Given this list of marker genes ZNF83, RPA1, NOTCH2NLA, PDGFA, RBFOX2, LLGL2, NTAN1, TPR, TTC3, AHSA2P, MAPK13, TLR5 (toll like receptor 5), DCPS, SAYSD1 (SAYSVFN motif domain containing 1), EXOC2, POGZ, RPS19, FNBP1, SPINT1, SOX13, DENND2B, DHRS7, PRRC2C, KDM5B, KLHL23, MGP, SEPHS1, KCTD3, ABHD3, DDR1, PRR15L, SREK1IP1, MATN2, INPP5A, MPZL1, IGF2, MARCHF3, PDCD4, TNFSF4, B4GALT3, ST14, ZSCAN18, IDUA, MMP11, CACNA1D, HNRNPA0, LAD1, ELP1, RPLP0, SREBF2, PLXNA2, CCZ1, CRNKL1 (NCBI Gene Id 51340), TTLL4, HIC2, MAP4K4, MEX3D, UBAP2, SOX9, S100A14, ABCC10, RABIF, NAP1L1, MYO5C, LMNA, PAIP1, ATP5MC2, RO60, ZNF143, NUP133, CLDN7, AHNAK, PIAS4, TMEM63A, STT3A, ADGRG1, RBM8A (RNA binding motif protein 8A), HOOK2, NRXN3, SMARCA1, F11R, ARHGEF3, NCOA3, PRP4K, PEG3, ADAR, PLPP2, SPINT2, EDEM3, C2CD5, BRD3, SMG7, DNAJC9, EPHB4, UBXN7, TIA1, FAM168B, LBR, ZNF551, RABGAP1, TAX1BP3, SETDB1, MYRF, TJP3, CXADR, CTNND2, SMARCC1, TRIOBP, ATP2B1, CDK19 (NCBI Gene Id 23097), NREP, ZNF468, ZNF165, ARID3A, SFI1, RPL17, here is a description of the gene set: Up-regulated genes in hepatocellular carcinoma (HCC) subclass G1, defined by unsupervised clustering from publication Boyault S, Rickman DS, de Reyniès A, Balabaud C, Rebouissou S, Jeannot E, Hérault A, Saric J, Belghiti J, Franco D, Bioulac-Sage P, Laurent-Puig P, Zucman-Rossi J (PMID 17187432) studied in species Homo sapiens Human Gene Set: BOYAULT_LIVER_CANCER_SUBCLASS_G1_UP Hepatocellular carcinomas (HCCs) are a heterogeneous group of tumors that differ in risk factors and genetic alterations. We further investigated transcriptome-genotype-phenotype correlations in HCC. Global transcriptome analyses were performed on 57 HCCs and 3 hepatocellular adenomas and validated by quantitative RT-PCR using 63 additional HCCs. We determined loss of heterozygosity, gene mutations, promoter methylation of CDH1 and CDKN2A, and HBV DNA copy number for each tumor. Unsupervised transcriptome analysis identified 6 robust subgroups of HCC (G1-G6) associated with clinical and genetic characteristics. G1 tumors were associated with low copy number of HBV and overexpression of genes expressed in fetal liver and controlled by parental imprinting. G2 included HCCs infected with a high copy number of HBV and mutations in PIK3CA and TP53. In these first groups, we detected specific activation of the AKT pathway. G3 tumors were typified by mutation of TP53 and overexpression of genes controlling the cell cycle. G4 was a heterogeneous subgroup of tumors including TCF1-mutated hepatocellular adenomas and carcinomas. G5 and G6 were strongly related to beta-catenin mutations that lead to Wnt pathway activation; in particular, G6 tumors were characterized by satellite nodules, higher activation of the Wnt pathway, and E-cadherin underexpression. CONCLUSION: These results have furthered our understanding of the genetic diversity of human HCC and have provided specific identifiers for classifying tumors. In addition, our classification has potential therapeutic implications because 50% of the tumors were related to WNT or AKT pathway activation, which potentially could be targeted by specific inhibiting therapies.